Given this list of marker genes NOTCH4, NOTCH3, NOTCH1, NOTCH2, LFNG, here is a description of the gene set: part of: Diseases associated with O-glycosylation of proteins The Fringe family (CAZy family GT31) of glycosyltransferases in mammals includes LFNG (lunatic fringe; MIM:602576), MFNG (manic fringe; MIM:602577) and RFNG (radical fringe; MIM:602578). Fringe enzymes function in the Golgi apparatus where they initiate the elongation of O-linked fucose on fucosylated peptides by the addition of a beta 1,3 N-acetylglucosaminyl group (GlcNAc). Fringe enzymes elongate conserved O fucosyl residues conjugated to EGF repeats of NOTCH, modulating NOTCH activity by decreasing the affinity of NOTCH extracellular domain for JAG ligands.<br><br>The spondylocostal dysostoses (SCDs) are a group of disorders that arise during embryonic development by a disruption of somitogenesis. The Notch signalling pathway is essential for somitogenesis, the precursors of vertebra and associated musculature. Defects in one of the Fringe enzymes, beta-1,3-N-acetylglucosaminyltransferase lunatic fringe (LFNG), can cause spondylocostal dysostosis, autosomal recessive 3 (SCDO3, MIM:609813), a condition of variable severity associated with vertebral and rib segmentation defects. Reactome Pathway: Defective LFNG causes SCDO3 studied in species Homo sapiens